Given this list of marker genes INSIG1, ATP6V1G3, AP3D1, HGS, VPS36, YIPF7, RAB8A, DIAPH3, VAMP3, TYRP1, CYLC1, PHETA2 (PH domain containing endocytic trafficking adaptor 2), GOLPH3L, EXOC8, SEC31B, VPS13B, BLOC1S3, TRAPPC10, DOC2B, CPLX1, VPS37A, POC1B, EEA1, TRAPPC6A, PRKCI, HPS4, MICALL2, ATP6AP1, VPS37C, RAB29, ZDHHC15, LAPTM4B (NCBI Gene Id 55353), TRAPPC4, SLC2A4, SPHK1, CHMP2B, CHMP4BP1, IST1, ANXA8L1, MX1, RAB20, PRKN, PDCL2 (NCBI Gene Id 132954), PAFAH1B1, TOM1, KCNE1, VTI1B, VPS4B, FNBP1L, SNX33, RAB34, ACRBP, YIPF4, SYT1, GARIN1B, AP1B1, STX19, FBXO5 (NCBI Gene Id 26271), CPLANE2, TMPRSS12, STX4, PIKFYVE, CHMP3, RPH3AL, ZFYVE16, ZDHHC2, OSBP, TMEM175, LRRK2, RAB22A, TRAPPC9, BET1, TBPL1, CCDC38, TRARG1, DCAF17, SNAP91, VAMP7, RFX2 (NCBI Gene Id 5990), MYO18A, SNF8, PRRT2, SNX19, STX7, ANKRD27, SYT5, DNM2, RAB5C, SYT2, USP8, VPS41, ATP6V1G1, RPH3A (NCBI Gene Id 22895), STXBP1, ARFGAP2, CD34, STX5, TRAPPC1, RUFY1, ACTL7A, AP1G1, VPS39, RILP, VIPAS39, RNASEK, SLC9A8, SEC16A, AP1S3, SEC24A, MIA3, AP3B2, SRGN, AQP11, RAB2A, SPG11, STX12, HPS3, CCDC136, VTI1A, PICALM, F2R, ARL8B, USP50, SDC4, PFN4, NKD2, DOC2A, USO1, PI4K2A, MVB12B, ATP6V0A1 (ATPase H+ transporting V0 subunit a1), CHMP1A, DNM1, ATP6V1B2, ATP6AP2, BLOC1S2, SEC24C, STX10, PPP6C, SYT8, ZPBP2, ZPBP, SURF4, MAPK15, STX3, CHN2, AQP1, BTBD8, RAB5B, TGFBRAP1, SNAPIN, SERPINE2, TFG, ATP6V0A4, ASIP, CUL3, ARFGAP3, SYT3, C2CD5 (C2 calcium dependent domain containing 5), CHMP1B, ZNRF2, RAB27A, PEF1, STAM2, GPR143, ABCA1, SAMD9, TMED10, STX17, SNAP29, STXBP6, STX1A, VPS8, LYST, STX1B, DNAJC13, AP3S2, ZNF385A, CORO1C, SYT9, HOOK1, GARIN3, VPS28, DTNBP1, SNCA, SEPTIN8, ATP13A2, VAMP4, SAR1B, UBAP1, SDC1, RAB4B, BAIAP3, CHMP2A, STX16, ANXA2, AP3S1 (NCBI Gene Id 89412), SNAP47, LAMTOR1, SHROOM2, SNX11, CHMP4B (charged multivesicular body protein 4B), SNAP25, STX11, CORO1A, ATP6V1F, RUFY4, HPS6, PMEL, C9orf72, TSG101, WASH3P, UVRAG, TMEM9, ATP6V0B, PDCD6, TBC1D20, BLOC1S1, TRAPPC12, VPS37D, TRAPPC2, IZUMO3, SOX30 (SRY-box transcription factor 30), MX2 (NCBI Gene Id 4600), P2RX7, ANXA8, STAM, RAB39A, VPS11, AP3M2, SNX10, HPS1, CLN3, RAB11A, GARIN1A, VPS25, DLG4, PLN, AP1S1, MFSD14A, ERC2, TMEM127, SQSTM1, SEC23A, GOLPH3, VPS18 (VPS18 core subunit of CORVET and HOPS complexes), VAMP2, IRAG2, ANKFY1, VPS37B, SCARB2, SLC35D3, HOOK3, ALS2, TRAPPC6B, DNM3, ATP6V1B1, RAB7B, RAB38, RAB7A, TRAPPC8, ATP6V1H, ATP6V0D1, CHMP7, AGFG1, PIP4K2A, SCAP, ATP6V1G2, STX2, PLEKHF1, CC2D1A, CPLX2, MYO7A, PREB, ANXA1, ATP6V1A, SORT1, KIF13A, RAB3A, TMF1, GOSR1, ATP6V1C1, SYT13, HID1 (NCBI Gene Id 80791), VAV3, CLCN3, SEC13, ATP6V1D, BLOC1S6, UBR4, CREB1, AP1S2, PHETA1, SLAMF1, ACTL9, ZNRF1, CHMP6, KLHL12, ATP6V0C, SPINK2, CPLX3, CSNK1D, CHMP4C, SYNJ1, VPS4A, VTA1, TRAPPC13 (NCBI Gene Id 80006), ZEB2, SNAP23, AP3B1, FASLG (Fas ligand), VAMP8, RAB32, TMED2, VPS33B, CHMP4A, GOSR2, PIP4K2B, TSNARE1, CHMP5, RAB14, RAB1A, WASL, WASHC5, ABCB6, PLA2G5 (NCBI Gene Id 5322), CLTRN, F2RL3, BACE2, CIDEB, PTPRN, SDCBP, PLA2G3, SYT7, AGFG2, S100A10, AP1M1, CPLX4, NECTIN2, WASHC4, CAV2, FHIP1B, BCL2, VAMP1, VPS33A, VAPB, SYT11, PIK3C3, TMCC1, TBC1D4, GRIK5, SEC23B, STX8, AKTIP, CAV1, PLEKHM1, KIAA0319L (NCBI Gene Id 79932), AP2M1, VPS16, ATP6V1E1, BLOC1S5, SEC24D, ARFGEF2, TMED9, CCDC42 (NCBI Gene Id 146849), AP3M1, RNF26, SEC31A, SAR1A, RUBCNL, EPS15 (NCBI Gene Id 2060), SLC17A7, HOOK2, SYP, SPPL2C, TRAPPC3, TRAPPC2B, HPS5, TRAPPC11, MVB12A, ZDHHC20 (zinc finger DHHC-type palmitoyltransferase 20), PLEKHA3, SPACA1, VAPA, PI4K2B, PLEKHJ1, GBF1, TRAPPC2L, YIPF5, PDCD6IP, SYT4, SRPX, APOE, KNL1, SEC24B, TRAPPC5, PLEKHF2, STX6 (NCBI Gene Id 102724791), BLOC1S4, SNX3, here is a description of the gene set: studied in species Homo sapiens Human Gene Set: GOBP_VESICLE_ORGANIZATION A process that is carried out at the cellular level which results in the assembly, arrangement of constituent parts, or disassembly of a vesicle.